The following is a description of a gene set: Our data indicated that activation of the PPARg nuclear receptor induces a retinoid response in human dendritic cells. In order to assess the contribution of retinoid signaling to the PPARg response we decided to use a combination of pharmacological activators and inhibitors of these pathways. Cells were treated with the synthetic PPARg ligand rosiglitazone (RSG), or with RSG along with the RARa antagonist (AGN193109) to block RARa mediated gene expression, or the RARa specific agonists (AM580) alone. This design allows one to determine if retinoid signaling is a downstream event of PPARg activation and what portion of PPARg regulated genes are regulated via induced retinoid signaling. Human Gene Set: GSE5679_RARA_AGONIST_AM580_VS_AM580_AND_ROSIGLITAZONE_TREATED_DC_UP studied in species Homo sapiens from publication Szatmari I, Pap A, Rühl R, Ma JX, Illarionov PA, Besra GS, Rajnavolgyi E, Dezso B, Nagy L (PMID 16982809) Genes up-regulated in monocyte-derived dendritic cells: AM580 versus rosiglitazone and AM580., and this is the list of marker genes: MAPKAPK2, GSTM4, STXBP1, ATP6V1H, SYPL1, AHI1, ZMAT5, ZBTB8OS, IL21, C16orf87, KRT222, AZIN1, PPP2R1B, EGLN3, PDCD1LG2, CD160, NDUFC1, ZIK1, GALM, CNTLN, TNC, CELA1, CETN2, BCL6, CTNND2, CFAP157, DESI1, PLEKHO1, SCCPDH, CYB5D2, CHDH, TOR2A, ARL2, COX6B2, MEF2B, ZWINT, LYL1, TUBB2A, POU2AF1, PXMP2, ANKRD46, MTCH2, CTSB, ALS2, MTX2, UAP1L1, USP6NL, ARC, CD22 (NCBI Gene Id 933), AP2M1, PLEKHG3, SAR1B, UBE2V1, DDX28, OAZ2, MFSD11, NRGN, C11orf58, JAZF1, TXNDC17, TOX4, ZNHIT1, SFMBT1, SERINC5, PTPN5, TNFSF14, MYO18A, FUCA2, FERRY3, NFATC1, LTBP1, CD80, HDHD3, PXMP4, RDH12, LAG3 (NCBI Gene Id 3902), SNX8, RNF157, IPMK, ICAM4, TRAPPC2, ANGPTL2, SOSTDC1, FCRL1, PTGER2, ZBTB3, SH3RF1, MAN2A1, NDUFB3, STX11, BMP2K, FAM156A (NCBI Gene Id 29057), CEBPA, MRPS21, CBR4, MPP1, JAK2, SMCO4, CD300LB (CD300 molecule like family member b), MMD, CACNA1S, PGPEP1, COPRS, KLHL4 (NCBI Gene Id 56062), EI24, DAPP1, TBC1D7, LPP, TNP2, SLC11A2, MAPRE2, UFC1, GPT2, SLIRP, FAM234A, TMEM106C, HMCES, SCRN3, CXCR5, RNF19A, CD81, FAM162A, AK7, SETD4, B9D2, DENND4C, NDUFS4, ZMAT2 (NCBI Gene Id 153527), UBAC2, FANCF, ZNF821, LMO4 (LIM domain only 4), ARMT1, PEX11A, S100A11 (NCBI Gene Id 6282), COLCA1, POGLUT3, NAXE, SNAI2, PTPN11, SLC45A4, TPD52, DYNLL2, CDK5R1, TRPM6, GNA14, GOLPH3L, PTRH1, NSG2, IL4, APOOL, UMAD1, VAMP5, TTC16, NUDT22, NT5C2, DOCK4, TUBB2B, DNAJC17, MICU1, CCDC28B, IRF8, HMOX1, NDUFA1, LMAN1, ALDOC, NPAS2 (neuronal PAS domain protein 2), EPDR1, TJP2, AK4, TBC1D24, DHCR7, HHEX (NCBI Gene Id 5556), NIT1, JDP2 (Jun dimerization protein 2), TMEM86A, ALAD, KCNQ5, TBC1D2B, ARFGEF3, LSM1, DHRS3, RAB11FIP4, NDUFC2, DUS2, STK39, FAM216A, LAMP2, PRXL2B, SLC22A15, MAFG, MSH6, TNFSF11, MDM1, PEAR1, IDE, FAM43A, CBX6, FAM241B